The following is a description of a gene set: Using whole-genome Affymetrix microarrays (HG-U133A), we characterized the transcriptome profile of cultured human macrophages stimulated for 4 h with interleukin 1 (IL-1) or interleukin 6 (IL-6). We found that, in distinction to liver cells, IL-1 is much more potent than IL-6 in modifying macrophage gene expression, although considerable heterogeneity in response of macrophages deriving from individual blood donors was observed. The obtained results permitted to identify a large number of cytokine-responsive genes. coding for proteins of unknown function that are now being studied in our laboratory. They may represent novel targets in the anti-inflammatory therapy. species: Homo sapiens Human Gene Set: GSE8515_CTRL_VS_IL6_4H_STIM_MAC_UP Genes up-regulated in comparison of untreated macrophages versus those treated with IL6. from publication Jura J, Wegrzyn P, Korostyński M, Guzik K, Oczko-Wojciechowska M, Jarzab M, Kowalska M, Piechota M, Przewłocki R, Koj A (PMID 18498781), and this is the list of marker genes: SLC26A3, MRS2, OMD, MS4A1, RAB11A, YAF2, KLRC3, SPRR1B, TBC1D8B (TBC1 domain family member 8B), SLC24A1, APBA3, OPRM1, STAM, ENTREP2, CHRNB3, FOXJ3, IBTK, PIK3C2G, ATXN8OS, GNG5, DSCR4, LRCH1, SEPTIN6, C1orf174, VEZT, HPRT1, PUS7, RNF187, TMEM131, ARK2N, PTPRT, MAU2, PPP6C, ZNF702P, KDM5A, CEP76, MBNL2, METAP1, CDC23, DUSP7, STK39, TEX30, TOB1, PPP2R5A, DCAF10, ZNF586, TRRAP, GNPAT (NCBI Gene Id 8443), TH, CYP3A43, STX6, UFSP2, TOB2, ANK2, MEGF9, CMAS, TSSK2, MCTP2, MAD2L1, MTFR1, GNAI1, TRIL, CLOCK, MRPS15, TTC27, CSN3, RNF11, KDM6A, EIF1AX, MYH7B, ALG6, SEC24B, EIF4G2, EHHADH, ZNF329, HJURP, FGF9, ZDHHC4, PPP2R5E, CASD1, PRIM2, SEC22A, OAZ1, BCL10, OSBPL1A, ITGB3BP (NCBI Gene Id 23421), RENBP, E2F3, MED7, ZPBP, PSMD1, FRAT2, SLBP, BLZF1, OR2S2, RPS17P5, PPP1CC, SRY, HSF2, DR1, ORC5, CEP85, XPNPEP1, ZNF394, ELF2, ERLIN2, GALNT7, MRPL33, TRIM36 (tripartite motif containing 36), RAB14, MEX3C, SMAD2, RAP1A, GALR3, PLS1, PIK3CB, MKLN1, EGLN1, MFSD11, ZFPM2, SCAF8, SLC17A3, ZFTA, TTI1, MAP3K4, PTGIS, IREB2, ZNF264, RP2, MYO1B, BPTF, PLAA, SLC16A6, PLCG2, GFPT1, CROT, RMND5A, STK38L, OR10H2, TAF1B, ZNHIT3, RANBP9, QRSL1, CENPN, SNUPN, SOWAHC, RNGTT, CD69, ZNF473, MEF2A, IL33, MOGAT2, MRPL3, MPL, ZNF764, RPL9, PHC3, SRR, AATK, SKIC8, CYP2D6, SLC12A5, TFB2M (transcription factor B2, mitochondrial), SARAF, ZNF552, HRAS, CSPG5, SS18L2, MCTS1 (MCTS1 re-initiation and release factor), CNGA3, NPTN, DDO, AIRIM, CHP1, DYM, SLIRP, SOAT1, CACNA2D3, CYP4F2, KIF11, CRISP2, ABCC9 (ATP binding cassette subfamily C member 9), SSX1, GHITM, SIKE1, MTCL1, TMED2, PPEF1, CFL1, CNIH1, PCSK1, TSPYL4, DNALI1, SEC61A2, C1D, NGRN, TFAP2C, LRRC37A2, PEX11A, DPF3